The following is a description of a gene set: studied in species Homo sapiens from publication Lake BB, Chen S, Hoshi M, Plongthongkum N, Salamon D, Knoten A, Vijayan A, Venkatesh R, Kim EH, Gao D, Gaut J, Zhang K, Jain S (PMID 31249312) Human Gene Set: LAKE_ADULT_KIDNEY_C6_PROXIMAL_TUBULE_EPITHELIAL_CELLS_FIBRINOGEN_POS_S3, and this is the list of marker genes: SLC34A2 (solute carrier family 34 member 2), PNRC1 (NCBI Gene Id 10957), LINC01320, TM9SF3, HSP90AB1, MT1G, KCNIP4, HINT1, FTL, LRP2, GLRX, RALGAPA2, FGB, AKAP12, RPS15 (ribosomal protein S15), ZBTB38, CTSL, SOD1, MACC1 (MET transcriptional regulator MACC1), BTG1, SSBP2, FMNL2, TKT, PTPRK, RPS23, ATP11A, EPS8, ADAMTS9-AS1, PARP14, CNKSR3, GCLC, CD59, SERPINE2, TGM2 (transglutaminase 2), NUFIP2, AGAP1, RNF213, CYB5A, ZFAND5 (NCBI Gene Id 7763), CCNL1, SEMA6A, KRT18, PLAAT4, CFI, PHLDB2, NRG1, SPAG9, NRP1, WWTR1, APOL6, SKAP2, SIPA1L1, FAM135A, ARHGEF3, SPATS2L, FCHO2, ZNF462, NLGN1, GALNT14 (NCBI Gene Id 79623), SLC27A2, RPL27, ITGB8, HOOK1 (NCBI Gene Id 51361), MSRA, SERPINA1, MACF1, CXCL14, H2AC6, AOX1, MAML2, GPX3, FBXL7, SLC3A1, CIB1, PLEKHA1, ENO1, HSPA9, SLC13A1, TXNRD1, CNN3, RPLP0, HSP90AA1, LINC00278, HSPA5, SLC22A2, NEAT1, FAU, RASSF4, RPS19, UNC5CL, PALS2, ASH1L, FGA, PRUNE2, VMP1, MGST1, CLU, STAT1, TMBIM6, EZR, RRBP1, PITPNC1, AGT, SVIL, SPP1, CHD1, TAX1BP1, CCT6A, CD24, PEBP1, ARHGAP5, CRYAB, ZNF292, RNF19A, ATM (NCBI Gene Id 8068), NCKAP5, PDZK1IP1, CANX, SERPINF2, SPTLC3, RPS20, SOD2, TNFSF10, LPGAT1, ALDH6A1, FTH1 (NCBI Gene Id 92182), L3MBTL4, DNAJC1, ACMSD, GULP1, RPS16, ASCC3, ZBTB20, CTSB, CLIC4, RHEX, SYNE2, HSPD1, SNX13, PLSCR1, VPS13A, GBP2, MAST4, FGGY, HLA-E, NT5C2, CNDP2, TMSB10, MIOX, DOK6 (NCBI Gene Id 220164), TRPS1, CALM1, DICER1, UGCG, CNTN4, CTSH (cathepsin H), FOXP2, LAPTM4A, LRRK2 (NCBI Gene Id 399472), TAF1D, TMTC2, PTGR1, OCIAD1, RPL18, SQSTM1, SMIM2-AS1 (NCBI Gene Id 101929212, SMIM2 antisense RNA 1), ABCC4, CAB39, CDH6, TINAG, ODC1, FNIP2, C6orf62, COBL, IL1R1, TFPI, GATM, NFIA, PLCH1, AHI1, KIF21A